Given this list of marker genes Ifi44 (NCBI Gene Id 99899), Slfn5, Irf7, Tespa1 (thymocyte expressed, positive selection associated 1), Zfyve19, Oas3, Mical1, Rtp4, Isg15, R3hdm2 (NCBI Gene Id 71750), Zbp1, Isg20, here is a description of the gene set: from publication Cui A, Huang T, Li S, Ma A, Pérez JL, Sander C, Keskin DB, Wu CJ, Fraenkel E, Hacohen N (PMID 38057668) Mouse Gene Set: CUI_ETAC_IFNA1_RESPONSE_UP Cytokines mediate cell-cell communication in the immune system and represent important therapeutic targets. A myriad of studies have highlighted their central role in immune function, yet we lack a global view of the cellular responses of each immune cell type to each cytokine. To address this gap, the authors created the Immune Dictionary, a compendium of single-cell transcriptomic profiles of more than 17 immune cell types in response to each of 86 cytokines (>1,400 cytokine-cell type combinations) in mouse lymph nodes in vivo. A cytokine-centric view of the dictionary revealed that most cytokines induce highly cell-type-specific responses. For example, the inflammatory cytokine interleukin-1β induces distinct gene programmes in almost every cell type. A cell-type-centric view of the dictionary identified more than 66 cytokine-driven cellular polarization states across immune cell types, including previously uncharacterized states such as an interleukin-18-induced polyfunctional natural killer cell state. species: Mus musculus Genes positively differentially expressed in cell type: eTAC (extrathymic Aire-expressing cell) upon treatment with cytokine: IFN-α1 in mouse lymph nodes in vivo.